The following is a description of a gene set: Human Gene Set: GSE5142_CTRL_VS_HTERT_TRANSDUCED_CD8_TCELL_EARLY_PASSAGE_CLONE_DN Genes down-regulated in CD8 T cells: control versus over-expressing TERT. from publication Menzel O, Migliaccio M, Goldstein DR, Dahoun S, Delorenzi M, Rufer N (PMID 16951325) studied in species Homo sapiens Using CD8+ T lymphocyte clones over-expressing telomerase weinvestigated the molecular mechanisms that regulate T cell proliferation. Transduction and subcloning procedures were performed on CD8 + naive T-cell clones isolated from two different healthy individuals aged between 30 to 35 years (HD1 and HD2). T-cell cloneswere transduced to express hTERT/GFP or GFP alone. HD2 was profiled on U133Plus 2.0 and submitted as a separate GEO series., and this is the list of marker genes: SYS1, ANAPC11, LIPT2 (NCBI Gene Id 650826), FLOT2, CAPN1, SCML4, SCN4A, RCC2, CCNE1, PGM3, TMEM204, GRIP2, IMPDH1, STMN1, FRAT2, ORAI2, UTP14A, TMEM200A, RIGI, RPSA, EEF2, DOK7, FNTB, GUCD1, TBL1X, ITK, ARHGAP29, ANKRD13A, DDX19A, GPR18, TTC7B, MED18, ZNF575, PDCD7, AZI2, GRAMD2B, KLF2, CALCRL, WDR43, MBOAT1, FAM162B, PKNOX1 (PBX/knotted 1 homeobox 1), VIPR1, PIK3IP1, ARV1, GPATCH4, ASAP1, RAB20, HID1, IGFBP4 (NCBI Gene Id 3487), TGFBR3, ADARB1, SMAP2, UFC1, FGD5, MRTO4, PUS1, ITPR1, DAPL1, OAS2, ENSA, RNF167, ABCC5, LHFPL2, EPOP, EMB, CADM3, ACTR5, EPB41L1, HS3ST3B1, PIK3CD, HIPK1, CHD4, APP, UGGT1, NR5A2, NINJ2, MTARC2, FAM234B, RPS2, ADA, SGK1, ZNF169, MAZ, PTGR3, SDHC, COQ8B, DROSHA, PTPRA, LRRC75B, GALNT9, CCDC180, SLCO4A1, NACC1, SEMA6C, GFOD2, PDK1, ARL4C, TXK, NME2, WDR83OS, PXYLP1, ESRRB, ASCL3, ATP8B4, ERP29, GPR183, CLYBL, TMEM267, ZNF784, RPL10, HIVEP2, RGMB, CNTFR, IFITM10, KIF1B, ASS1, SNX15, METTL9, KLHL15, NAT10, PIAS1, SEPTIN6, PCBP2, ACTN1, RSU1, HMGA1, CAMKV, GEMIN6, MAP1LC3A, PPP6R1, DPYSL4, AUTS2, THEMIS, CFAP45, APLP2, VWCE, E2F5, SHLD1, SEMA6A, GARIN1B, PPP6R3, GFRA4, RPS6 (NCBI Gene Id 92956), ADSS2, POLR2M, SUV39H1, RRP12, CYP2D6, CSNK1G2, PDLIM4, RFLNB, IPO13, DNTT, NXPH3, CHD7, RAB11FIP4 (NCBI Gene Id 85018), CPM, TTC27, FCGR2A, CFAP298, DPH1, IL17RC, XKR5 (XK related 5), TSPAN14, EVC, DIDO1, NDUFS4 (NADH:ubiquinone oxidoreductase subunit S4), ACP3, WEE2, PPIC, CAP1, ATP8A2, ABHD15, CSTF1, ENC1, LIMS4, SLC2A5, PUS7L (pseudouridine synthase 7 like), SCP2, SERPINA3, IL7R, SNAPC1, CASP14, CHP1, FAM78A (family with sequence similarity 78 member A), CSDC2, COX16, CALB2, DHRS13, GPSM2, SLCO3A1, TM9SF4, OXCT1, RTN4RL1, IBTK, CALHM6, RNF32, ADD3, SLC39A14